Given this list of marker genes Fam222a (family with sequence similarity 222, member A), Kmt2d, Ndufa4, Gpd1l, Ncam1, Acvr1b, here is a description of the gene set: Genes predicted to be targets of miRBase v22 microRNA mmu_miR_210_3p in miRDB v6.0 with MirTarget v4 prediction scores > 80 (high confidence targets). from publication Chen Y, Wang X (PMID 31504780) Mouse Gene Set: MIR_210_3P studied in species Mus musculus